Given this list of marker genes SLC1A1, SLC3A1, SLC7A7, SLC6A19, CLTRN, SLC7A9, SLC3A2 (NCBI Gene Id 6520), SLC6A20, SLC36A2, here is a description of the gene set: studied in species Homo sapiens Amino acid transport defects (IEMs) Human Gene Set: WP_AMINO_ACID_TRANSPORT_DEFECTS_IEMS